Given this list of marker genes CCDC28B, GRIN3B, MTA1, SIRT5, PLA2G4C, VTN, LCLAT1, PTPN13, REEP6, MPG, S100A10, CHRNA9, C19orf12, HNF4A, CBX2, PPCDC, RNF167, RSPH14, C12orf57, APEX1, FOXRED2, GRAP, CELSR3, AKAP12, CCDC28A, FILIP1L, KRTCAP3, PACS1, TPP1, NAGA, SCP2D1, SUN3, DOP1B, ANXA8, SLC8B1, CACNB4, SULT6B1, SNRK, XRCC6, TNN, RXRA, BACE2, NUMA1, ID4, PCDHB15, GLB1, EBI3, BCO2, FGD2, LIFR, TEX48, PKDREJ, CD7, MEIS3, DYM, EPB41L1, GCFC2, STARD3, STX2, NLRP5, PLEKHN1, RETSAT, CCDC198, TMEM138, ZNF688, TYK2, CD1D (NCBI Gene Id 912), SERPINC1, SPO11, IFT74, CDH3, CCKBR, GIT2, CEP95, NENF, GOLT1A, PDCD2L, RFTN1, ACAA2, CFAP251, TMEM234, HVCN1, SYNJ2, IL4I1, RCN1, ZBED5, PGC, SLC25A45, DES, SCML4, INKA2, NPY2R, CEL, TBC1D22A, EDN2, RNASE4, NKX3-1, TSPAN32, SQOR, WFIKKN2 (NCBI Gene Id 124857), KCNH1, FMO5, PRKACB, SEC14L2, CEP83-DT (CEP83 divergent transcript), SCN1B, CD109, UNC119, GAD1, RNF130, NRIP3, CCNDBP1, TACC2, FHL1, HPCAL4, CD79B, SNHG32, YBEY, FAT1, BCKDHA, CAPN5, SYT7, THAP11, TIFAB, PTPN1, PRR5L, HAUS1, GPANK1, ELP3, CREBBP, OTX1, RABAC1, CATSPERD, CARD6, EXTL1, ART4, CPNE4, TRIM10, CRYZL1, SSH3, GARIN3, CPLX1, GRIK5, ASAP3, STAT4, C4orf51, COL26A1, RFX5, SLC35F6, METTL8, HACD2, NUDT16, HEPACAM2, ELF2, NUDT6, FAM110D, OSCP1, CABS1, IFT172, IST1, TMEM63A, PTPN18, RENBP, NNMT (nicotinamide N-methyltransferase), PRPF6, ARMC2, KREMEN1, ZNF524, DTX3, THAP2, VPS16, SIK3, PRSS55, ARL4D, PKN3, TXNRD2, CLUAP1, ATP1A3, YPEL1 (yippee like 1), MAP1LC3B, KAT8, HLA-DMA, ATMIN, ELAVL4, ZNF827, SCNN1G, FNDC7, CCR6, TRPC7, STXBP4 (syntaxin binding protein 4), TAFA1, ANKRD13D, PDC, AP3B1, OGN, CRYGS, HIP1R, TTC21B (tetratricopeptide repeat domain 21B), MS4A6A, here is a description of the gene set: Th1 and Th2 cells arise from a common precursor cell in response to triggering through the TCR and cytokine receptors for IL-12 or IL-4. This leads to activation of complex signaling pathways, which are not known in detail. Disturbances in the balance between type 1 and type 2 responses can lead to certain immune-mediated diseases. Thus, it is important to understand how Th1 and Th2 cells are generated. To clarify the mechanisms as to how IL-12 and IL-4 induce Th1 and Th2 differentiation and how TGF-beta can inhibit this process, we have used oligonucleotide arrays to examine the early polarization of Th1 and Th2 cells in the presence and absence of TGF-beta after 0, 2, 6 and 48 hours of polarization. studied in species Homo sapiens from publication Lund R, Aittokallio T, Nevalainen O, Lahesmaa R (PMID 14607935) Genes up-regulated in CD4 T cells activated by anti-CD3 and anti-CD28: TGFB1 and IL4 (2h) versus IL4 (2h). Human Gene Set: GSE2770_TGFB_AND_IL4_VS_IL4_TREATED_ACT_CD4_TCELL_2H_UP